Given this list of marker genes DUSP7, DUSP8, DUSP3, DUSP4, PTPRR, PTPN7, DUSP5, DUSP2, MAPK10, DUSP16, MAPK9, DUSP1, MAPK1, DUSP10, MAPK8, MAPK14, DUSP9, MAPK3, PTPN5, DUSP6, here is a description of the gene set: Regulation of GF-RTK-RAS-ERK signaling, PTP. Pathway ID: N01593. Pathway type: Reference. Pathway class: nt06526 MAPK signaling. Pathway Definition from KEGG: (PTP,MKP) -| (ERK,JNK,MAPK14) studied in species Homo sapiens Human Gene Set: KEGG_MEDICUS_REFERENCE_REGULATION_OF_GF_RTK_RAS_ERK_SIGNALING_PTP